The following is a description of a gene set: The directed movement of catecholamines, a group of physiologically important biogenic amines that possess a catechol (3,4-dihydroxyphenyl) nucleus and are derivatives of 3,4-dihydroxyphenylethylamine. Human Gene Set: GOBP_CATECHOLAMINE_TRANSPORT studied in species Homo sapiens, and this is the list of marker genes: TGM2, KCNA2, KCNB1, GABBR1, GRM2, CHRNA4, SNCG, SNCA, ABAT, CRH, MECP2, ADORA2A, ADORA3, SLC6A2, SLC22A3, MAPK15, ADRA2B, KPNA4, SLC18A2, OPRK1, SLC22A2, DTNBP1, SDHD (succinate dehydrogenase complex subunit D), SLC22A1, ACTB, GDNF, OXT, RAB3B, PRKN, FFAR3, COMT, SYT1, GNAT1, SLC29A4, GHSR, STX1A, SLC29A3, PARK7, SLC18A1, DRD4, GRK2, CXCL12, P2RY1, FGF20, CHRNA6, ADRA2A, TOR1A, NPY2R, SYT11, SYT4, CHRM5, DRD2, CHRNB2, ADRA2C, SLC6A3, HTR2A, PINK1, VIP, DRD3, CARTPT, DRD1, CHGA